Given this list of marker genes SOX6, HOXB4, SIRT6, PTN, NKX2-5, RBM24, FGF2, TGFB2, SOX5, LTBP3, NUDT21, TCF15, MTCH2 (mitochondrial carrier 2), NR6A1, FOXC1, SOX17, SOX9, SP7, TACSTD2, DHX36, TBX5, PWP1, NR5A2, here is a description of the gene set: Any process that activates or increases the frequency, rate or extent of stem cell differentiation. studied in species Homo sapiens Human Gene Set: GOBP_POSITIVE_REGULATION_OF_STEM_CELL_DIFFERENTIATION